Given this list of marker genes Cblif, Abcd4, here is a description of the gene set: electronically inferred by orthology from the curated human pathway This event has been computationally inferred from an event that has been demonstrated in another species.<p>The inference is based on the homology mapping from PANTHER. Briefly, reactions for which all involved PhysicalEntities (in input, output and catalyst) have a mapped orthologue/paralogue (for complexes at least 75% of components must have a mapping) are inferred to the other species. part of: Cobalamin (Cbl, vitamin B12) transport and metabolism studied in species Mus musculus Reactome Pathway: Uptake of dietary cobalamins into enterocytes